Given this list of marker genes ZAP70, CARD11, FURIN, RPS20 (NCBI Gene Id 6224), EEF1D, HNRNPA2B1, TSPYL2 (NCBI Gene Id 64061), GABARAP, CLK1, MYO5A, PPIA, CARD8, PRDM2, EVI2B, STK17B (NCBI Gene Id 9262), RPS15A, APOBEC3C, MCL1, SAP18, CDC42SE2, PLEKHA2, AKAP13, PLEKHO1, YWHAZ, RPL17, ATP2A3, HSP90AA1, RAC2, RPL10, PTP4A2, TRIB2, ZFP36L1, MSN, RORA, PDE4D, RNASEH2B, SIT1, DAXX, FCMR, STK17A, UGP2, FLNA, CREBBP, RAPGEF6, ZFP36, RPL28, RPS5, PAXX, CHST12, DNAJA1, IL18RAP, MBD2, TMEM50A, NLRC5, PTGDS, WDR1, ATXN2L, TOMM7, POLR3GL, RBM3, VEGFB, ZYX, PRKCB, NUCKS1, COTL1, UBC, CAPG, CD84, PRRC2C, ELOVL5, GVINP1, JUN, RPS9, H1-10, OGA, ARPC5, LBHD1, PCNX1, SASH3, SBNO1, KMT2A, TAPBP, VIM, CYFIP2, CALM1, EIF1, RALGDS, EMB, TSC22D3, ACTR2, PSMB10, PNRC1 (NCBI Gene Id 10957), QRICH1, RAB3GAP2, C21orf91, RAP1A, BBLN, LAT, PFN1, TNFRSF18, DENND2D, ANKRD12, HLA-F, THEMIS, PCBP1, DDIT4, UNC13D, HERC1, SH2D3C, PHTF2, GATAD2B, NIN (NCBI Gene Id 57681), ANAPC16, DEF6, SHISA5, RPL9, INPP5D, TRMT112 (tRNA methyltransferase activator subunit 11-2), SRSF5, SMDT1, DCP2, CYLD, SIGIRR, DUSP1, APBA2, TUBB, DDX17, ARPC4, RPS13, AAK1, HNRNPK, ITK, CST7, LPXN, ADAR, CCND2, SH3BGRL3, LDHB, FAM78A, SIRT2, GMFG, ZFP36L2, PTGER2, LIMD2 (LIM domain containing 2), GIMAP2, ADGRE5, CTSW, TNRC6B, GIMAP4, TPT1, RPS21, BTG1, NMUR1, ELF1, SRSF2, FKBP1A, BIN1, SF3B4, ITGA1, SSBP4, ST3GAL5, PTPN22, MYADM, GNG2, LITAF, TTC1, OSTF1, CD8B, IL7R, PIP4K2A, TIGIT (NCBI Gene Id 201633), HNRNPC, DNAJB1, RPL39, YPEL5, TMSB10, CMTM6, ADCY7, RPL37A (ribosomal protein L37a), WAS, ATP6AP2, SMARCA2, IL16, EVI2A, RPL13AP3, RACK1, RPL36, TLN1, LCK, SARAF, GZMA (granzyme A), SUMO2, ITGB7, S100A4, TRIR, HLA-C, RGS19, RPL7, CHD3, HIC1, SLC66A3, LBH (LBH regulator of WNT signaling pathway), GNPTAB, RGS10, GZMB, GLIPR1, PBXIP1, TCIRG1, RPS27, APBB1, RPL32, UBA52 (NCBI Gene Id 7311), RPL12, TBC1D2B, ITSN2, DAD1, C19orf53, ADAM8, SIRPG, RPL38, TNF, PTPRCAP, HMGN1, PARP8, ABRACL, HECA, PLXDC1, RPS4X, PARVG, RPL10A, CD300A, TXNIP, CD4, PTPN4 (NCBI Gene Id 5775), RHOG, RPS15, UCP2, CD2, CD244, RNASET2, HMGN4, CCR9, CMTM7, GNLY, RPL4, DOCK11, GLIPR2 (GLI pathogenesis related 2), SLA2, NLRC3, LSS, SLA, MS4A2, CDV3, ATF7IP, SEMA4D, CSRNP1, SPOCK2, RPL41 (NCBI Gene Id 6171), RESF1, SLC38A2, RPLP0, FLT3LG, RBM39, IL2RG, PSME1, NXF1, SH3BGRL, STOM, VAV1, JAML, PAIP2, PLEK, MYBL1, HEG1, SNRNP200, RAB27A, TMC8, TSC22D4, TYK2, NENF (neudesin neurotrophic factor), UBE2I, CRIP1, IL32, IL2RB, PPIG, MYL12B, WTAP, SH2D2A, HCLS1, TLE5, TGFBR1, MYH9, TAGAP, FKBP11, MIAT, TOP2B, PTPN6, LINC00674, ASXL2, SEPTIN9, RSU1, SAMD9, SLC38A1, BTN3A1, NCL, CRLF3, ZNF609, MKNK1, SLC12A6, WDR82, RPS4Y1, RPLP2, DUSP2, PTK2B, MBNL1, HIPK1, IFITM1, CALHM2, PTPN7, SNRPB, ANKRD13D, HNRNPDL, NFATC2, NFATC3, ARHGAP30, CD5, RPL14, ITGA4, POLR2K, TCF7, CD81, TES, RAP1B, CCL4, RPL34, CAP1, PSD4, GRK2, NUP210, DRAP1, GNAI3, TGFBR2, SYNE2, METTL9, IFITM2 (NCBI Gene Id 10581), SSR2, MYCBP2, CAPZB, CAPZA1, RPS6KA3 (ribosomal protein S6 kinase A3), PCM1, OAZ1, NHERF1, JUNB, JADE1, PITPNC1, NBEAL2, HP1BP3, GRAMD1A, GPR82, RPS25, CNTRL, MOB3A, TMSB4X, EEIG1, ZBTB4, PIK3IP1, RNF139, WIPF1, NPM1, RPS16, ICAM3, SUSD3, RPL19, PTPN2, HSPA8, BRK1, SLC7A5P2, SEPTIN1, CKLF, ARHGEF6, XCL1, SHFL, APOBEC3G, SPRY1, FOXO1, TPP1, TSPAN14, SCAMP3, RPL3, EVL, HCP5, TAB2, CHD2, KIT, LSP1, HLA-DPB1, DENND1C, CYBA, IQGAP1, ARHGEF3, ARHGAP25, SYTL3, KMT2E, MIR23AHG, UBB, ARHGAP4, DIAPH1, HLA-E, SYNRG, ARHGEF1, USP20, RPL35A, ANXA1, SELPLG, ZNF652, CD101, JAK3, CD69, CD47, ACTB, CNOT6L, OGT, XPO6, ATP8A1, SKAP2, SELENOH, PPP2R5C, CCNI, AKNA, FNBP1, PLEKHF1, FOS, SUN2 (NCBI Gene Id 25777), CLEC2D, ZNF217, CD3G, DDX5, PRKCQ, KPNB1, EID1, PRKDC, ARPC1B, LRRFIP1, PPP1R15A, RPL11, EIF3F, CTSC, RFLNB, DNMT1, FOSB, C12orf57, CHSY1, ALOX5AP, CYTH4, CLIC1, HLA-DPA1, CHST11, ARHGAP45, CDK6, KLRD1, ZNF655, GNAS, SACS, CD6, GYPC, SRSF7, ABHD14A, CD37, SET, RGS14, RPS6, TAOK1, PTPRC, ENSA, RPS11, LPIN1, CD7, SNTB2, ITGB2, PSMB4, PFDN5, ETS1, YME1L1, RPS12, OXNAD1, C9orf78, PCED1B, FLOT2 (flotillin 2), ACTG1, ITM2C, STK4, SUB1, MBNL3, MYO1G, YWHAB, STN1, ARL4C, JADE2, CYTIP, SCML4, SAMD9L, IKZF3, CLEC2B, CD48 (CD48 molecule), GZMM, YBX1, ENTPD1, AIP (NCBI Gene Id 9049), GNB1, RPL31, IL10RA, IDS, PPP6R1 (protein phosphatase 6 regulatory subunit 1), STAT3, CDC42EP3, VAMP2, OST4, MAP4K1, PSIP1, KLF12, BRD2, KDM2A, NKTR, CD9, ABCB1, NR4A2, ABHD17A, RPS14, ACAP1, PVRIG, TMIGD2, ITM2B, TRG-AS1, TBCC, MYL6, APBB1IP, RPL23A, SLFN5, CCR5, GIT2 (GIT ArfGAP 2), PPM1K, RASAL3, NAP1L1, ARF6, PAG1, PSMB8-AS1, CFL1, HOPX, SH2B3, SMAP2, UBE2D2, CYRIB, ARRB2, FCER1G, DHRS7, SLAMF7, GRK6, CISH, TRAF3IP3, ABI3 (ABI family member 3), LDLR, TBCB, ZC3HAV1, RPS10, CD3D, ATP2B4, DNAJC8, PIK3CD, RGS2, RPL27, CHURC1, RPS23, SNRPB2, LGALS1, CTDNEP1, CMTM3, RPL18A (NCBI Gene Id 6142), POU2F2, CBFB, CDC42SE1 (CDC42 small effector 1), RPL18, INPP4A, CD44, ATM, RPS7, BTF3, RPS3, MYL12A, SH3KBP1, RPLP1, SFPQ, KLRB1, XRCC6, RASSF5, IFI16, TUBA1A, CSTB, CREM, CIB1, WDR26, UBL5, ROCK1, PRKCH, BCL2, NOP53, DOCK8, RGS1, ARHGDIB, SLC2A3, ATP5MC2, LCP1, B2M, CYB561D2, SLC7A6, HNRNPH1, CITED2, RPL24, CD8A, CD3E, SEPTIN7, RPS27A, GLCCI1, EEF1G, SSH1, MATR3, TTC39C, NR3C1, LY6E, MEA1, PRKAR1A, ANXA6, DOCK2, BUB3, ARL6IP5, ST3GAL1, RNF166, TERF2IP, RPS3A, LINC02591, EPS15, PPT1, RBL2, TOR1AIP1, MYO1F, RPL15, GPR171, PPP1R12A, JAK1, FDFT1, EIF4G2, RPL35, PPP1R18, ESYT2, RNF44, ARHGAP9, TMC6, RBM26, SERINC1, RASGRP1, LDLRAD4, PHF1, IDI1, SYNE1 (spectrin repeat containing nuclear envelope protein 1), CXCR3, SRPRA, CDC42, HLA-A, RPS19, PHF20, GATA3, PSMA5, TNK2, SF1, OSTM1, PGK1, PPP1CA, LEPROTL1, PGC, TARP, NCKAP1L, ARHGDIA, RPL22, KIF21B, FYN, COMMD6, CD160, BZW1, HELZ, GIMAP7, BPTF, H3-3B, RBMS1, RPL23, TNFSF12, RPS18, DDX24, IKZF1, ITGAL, EIF4E3, CEP85L, ARGLU1, SMURF2, BCLAF1, CCND3, LAIR1, PRKACB, TPSB2, CPA3, KLF6 (NCBI Gene Id 8025), ARID2, SKP1, RHOH, ARAP2 (ArfGAP with RhoGAP domain, ankyrin repeat and PH domain 2), TRIP12, MDFIC, ADD1, INSIG1, HNRNPD, BCL11B, SEC62, ZNF207, UHMK1, CCT2, CD96, SFMBT2, CD247, ITGAE, PIM1, TAF7, MSH3, ARID1A (AT-rich interaction domain 1A), JUND, MAPK1, RNF4, BIN2, RBX1, TACC1, GIMAP1, CD52, LSM2, GIMAP6, PLAAT4, MDM4, RPL6, DEK, KLF13, SLC16A7, PKN1, ACTR3, ATP6V0E1, CELF2, CTBP1, TMEM245, FXYD5, RPL26, LAPTM5, DOCK10, FERMT3, SKAP1, ASB2, MAPRE2, CELF1, MBP, PRF1, PLCB2, PKM, SNHG1, DDX21 (NCBI Gene Id 9188), RNF149, SON, TRADD, RPS2, ITM2A, AUTS2 (activator of transcription and developmental regulator AUTS2), PREX1, TYROBP, TRA2B, EIF4H, RPL30, CCL5, RPS28, MYO9B, PSMB9, CD53, EIF4A2, EIF3G, RPS29, UBE2D3, TMA7, TSEN54 (NCBI Gene Id 283989), WNK1, SELENOT, CORO1A, TMEM123, CNN2, APOBR, PRPF38B, CCT4, LIMS1 (LIM zinc finger domain containing 1), WAC, SIPA1, STK10, PDE7A, SEPTIN6, ZNF292, ARL2BP, TGOLN2, RIN3, TRAPPC1, MAPK1IP1L, OSBPL8, PPP1R16B, GPSM3, RHOA, ESYT1 (extended synaptotagmin 1), UBAC2, REST, RNF167, MECP2, FAU, GYG1, FBXW7, SRGN, ARPC2, SERF2, AOAH, PELO, DDX6, CCNL1, STAT4, ATP6V1E1, NKG7, ELK4, TXLNGY, IRF1, RAPGEF1, USP47, RPL29, PDCD4 (NCBI Gene Id 27250), HCST, EMP3 (epithelial membrane protein 3 (MAM blood group)), PLP2, CNPY3, FUS, SRSF3, NFKBIA, NUCB2, TRAT1, PTBP3, TPM4, ARPC3, UBASH3B, KLC1, TNFAIP3, RUNX3, SNRNP70, RPL13, GSE1, FMNL1, MACF1, DAZAP2, TRAM1, SPCS3, CXCR4, SAMSN1, MLLT6, KCNAB2, LCP2, HMOX2, TPM3, SP110, SERP1, MAP2K1, ID2, HLA-B, CCR6, SAR1A (NCBI Gene Id 56909), SH3BP1, CLDND1 (claudin domain containing 1), PTMA, EEF1A1, SNX17, FAM89B, DDX3Y, CHD4, GNAI2, NEDD9, SETX, TNRC6C, RPL5, PSTPIP1, SPN, UTRN, RPL37, MORF4L1, CCDC69, SLC44A2, EIF4B, RAB8B, PPP3CA, TRIM22, PTGER4, PRRC2B, ANKRD44, KAT6A, LTB, FYB1, TBC1D10C, STX16 (syntaxin 16), RPL27A, here is a description of the gene set: studied in species Homo sapiens Human Gene Set: BUSSLINGER_DUODENAL_IMMUNE_CELLS from publication Busslinger GA, Weusten BLA, Bogte A, Begthel H, Brosens LAA, Clevers H (PMID 33691112)